The following is a description of a gene set: Genes down-regulated in CD11b+ cells from BALB/c mice bearing C26GM colon carcinoma: spleen versus tumor. Tumor growth is associated with a profound alteration of myelopoiesis, leading to recruitment of immunosuppressive cells known as myeloid-derived suppressor cells (MDSCs). Analyzing the cytokines affecting myelo-monocytic differentiation produced by various experimental tumors, we found that GM-CSF, G-CSF, and IL-6 allowed a rapid generation of MDSCs from precursors present in mouse and human bone marrow (BM). BM-MDSCs induced by GM-CSF+IL-6 possessed the highest tolerogenic activity, as revealed by the ability to impair the priming of IFN- -producing CD8+ T cells upon in vivo adoptive transfer. Moreover, adoptive transfer of syngeneic, GM-CSF+IL-6-conditioned MDSCs to diabetic mice transplanted with allogeneic pancreatic islets resulted in long term acceptance of the allograft and correction of the diabetic status. Cytokines inducing MDSCs acted on a common molecular pathway. Immunoregulatory activity of both tumor-induced and BM-derived MDSCs was entirely dependent on C/EBP transcription factor, a key component of the emergency myelopoiesis triggered by stress and inflammation. Adoptive transfer of tumor antigen-specific CD8+ T lymphocytes resulted in therapy of established tumors only in mice lacking C/EBP in myeloid compartment. These data unveil another link between inflammation and cancer and identify a novel molecular target to control tumor-induced immune suppression. We used gene expression analysis to identify those factors, secreted by tumor-infiltrating MDSC, which could drive emathopoiesis. Moreover we compare gene expression profile of tumor-induced MDSC, obtained from either the spleen and the tumor infiltrate of tumor bearing mice, and in vitro bone marrow-derived MDSC. species: Homo sapiens Human Gene Set: GSE21927_SPLENIC_VS_TUMOR_MONOCYTES_FROM_C26GM_TUMOROUS_MICE_BALBC_DN from publication Marigo I, Bosio E, Solito S, Mesa C, Fernandez A, Dolcetti L, Ugel S, Sonda N, Bicciato S, Falisi E, Calabrese F, Basso G, Zanovello P, Cozzi E, Mandruzzato S, Bronte V (PMID 20605485), and this is the list of marker genes: TXNIP, CCNL2, TRIOBP, BNIP3L, CRYL1, OSER1, WBP1L, FBXL5, INTS8, CD99, GMFG, P2RX4, N4BP2L2, STK25, PLEKHM1, CES2, CMC4, NKTR, PNRC2, ABAT, SIRT7, TMEM260, MZF1, TUG1, RAB4B, GCC2, FOXJ3 (NCBI Gene Id 22887), SPG11, BMAL1, FCGR3B, SON, ABI1, ZNF133, DET1 (NCBI Gene Id 55070), RIOK3, TSC22D1, TERF1, CASC3, CMPK1, KMT5B, INSIG2, ZBTB40, TRIB2, RABAC1, DEFB1, CLASP1, ZC3H11A, ZNF266, MYCBP2, KLF12, PAN2, SNRK, HNRNPA3, HSPBAP1, DIP2C, IDUA, MPPE1, UBA7, ZFAND6, BTN2A1, ZNF862, DYNLT3, P4HTM, RPL36A, LIPT1, C2orf68, PIPOX, PRKAB1, BLTP1 (NCBI Gene Id 84162, bridge-like lipid transfer protein family member 1), CALHM2, EPM2AIP1, BACH1, RPL27, ZNF586, PRPSAP1, RBL2, CSNK1D, ARL6IP5, ANKRD49, CPNE3, ADD3, PIK3CA, SPTAN1, NFRKB, USPL1, TRIM52, WWP1, ZNF83, GABARAPL2, ABHD17A, ARGLU1, ASB1, LONP2, ABCC5, EFNA1 (NCBI Gene Id 1942), TTC17, ARHGAP15, TXK, TRAF5, CDC14A, ATRX, CLK4, THBS3, RSRP1, STAT4, FBXL12, CTDSP1, CERT1, NCOR1, CD96, ATG13, MACF1, MAP4K1, STAG2, EVL, TAF1, FEZ2, IGFBP3, CTBS, PLEKHO1, CITED2, BAZ2A, ZNF337, PAFAH1B1, EGLN2, CREBL2, EVI2A, SRSF11, ARAP1, CLK1, AZU1, GATAD1, CCNG1, DHRS1, VEZF1, ECHDC2, ARL2BP, TECPR2, EPHA1 (EPH receptor A1), FBXO9, FRYL, FOXN3, SETD2, ICAM3, PIK3CD, S100A10, TOB1, JRK, SLC35E2A, PRKCZ, AFTPH, OVGP1, FCHO1, ACAP1, CYLD, BCL2L2, EFHC1, MAML1, ALG13, WSB1, CEP350, LPAR1, NR1D2, MON2, ARHGAP1, HIPK1, ATP6AP2, ZNF611, NISCH, SH2B1, LEMD3, PTCH1, GOLGA8A, TMEM80, PIP4K2B, LDOC1, MAN1A2, TSC22D3, METTL9, IST1, TNFRSF1A, CIRBP, WIPF2, ERBIN, KLRC3, VWA5A, PRSS23, TRAPPC10, LSS, VAMP1, RBM5, BRD1, ITGA4, CD6, MAU2, GALNT11, S100PBP, BBX